Given this list of marker genes GAP43, ROBO2, APP, ROBO3, EFNB3, FOXG1, ROBO1, here is a description of the gene set: Human Gene Set: GOBP_AXON_CHOICE_POINT_RECOGNITION studied in species Homo sapiens The recognition of molecules at a choice point by an axon growth cone; at a choice point the growth cone determines the direction of its future growth.